Given this list of marker genes ERF, GDF5, TBX5, HOXD13, MYCN, SRCAP, RUNX2, INTU, here is a description of the gene set: Human Gene Set: HP_SHORT_MIDDLE_PHALANX_OF_THE_2ND_FINGER Short middle phalanx of the 2nd finger species: Homo sapiens Hypoplasia (congenital reduction in size) of the middle phalanx of the second finger, also known as the index finger.